Given this list of marker genes PRMT8, CYFIP1, CTTNBP2, RHOA, AMOT, BAIAP2, ITSN1, here is a description of the gene set: Human Gene Set: GOBP_REGULATION_OF_MODIFICATION_OF_POSTSYNAPTIC_ACTIN_CYTOSKELETON species: Homo sapiens Any process that modulates the frequency, rate or extent of modification of postsynaptic actin cytoskeleton.